The following is a description of a gene set: Vaccination with attenuated live varicella zoster virus (VZV) can prevent zoster reactivation, but protection is incomplete especially in an older population. To decipher the molecular mechanisms underlying variable vaccine responses, T- and B-cell responses to VZV vaccination were examined in individuals of different ages including identical twin pairs. Contrary to the induction of VZV-specific antibodies, antigen-specific T cell responses were significantly influenced by inherited factors. Diminished generation of long-lived memory T cells in older individuals was mainly caused by increased T cell loss after the peak response while the expansion of antigen-specific T cells was not affected by age. Gene expression in activated CD4 T cells at the time of the peak response identified gene modules related to cell cycle regulation and DNA repair that correlated with the contraction phase of the T cell response and consequently the generation of long-lived memory cells. These data identify cell cycle regulatory mechanisms as targets to reduce T cell attrition in a vaccine response and to improve the generation of antigen-specific T cell memory, in particular in an older population. Genes negatively correlated with expansion of VZV specific T cells (0d to peak) in peripheral blood mononuclear cell in seniors (50-75) after exposure to Zostavax, time point 1D from publication Qi Q, Cavanagh MM, Le Saux S, Wagar LE, Mackey S, Hu J, Maecker H, Swan GE, Davis MM, Dekker CL, Tian L, Weyand CM, Goronzy JJ (PMID 27764254) species: Homo sapiens Human Gene Set: QI_PBMC_ZOSTAVAX_AGE_50_75YO_CORRELATED_WITH_EXPANSION_OF_VZV_SPECIFIC_T_CELLS_TO_PEAK_AT_1DY_NEGATIVE, and this is the list of marker genes: TOMM7, H4C3, SF1, DPP9, NSUN5, GIMAP5, EEF1B2 (NCBI Gene Id 1933), TPT1, STAG3L2, MCOLN1, RAD23A, PSMA3, TXNDC17, PSMA6 (proteasome 20S subunit alpha 6), COX6C, FUCA2, VTI1B, GNL3L, ARID4B, BOLA2, ATP5PF, MRPL23, TRIM25, DHX29, CHRNB3, ELMOD3, BNIP3L (BCL2 interacting protein 3 like), AP2S1, SERF2, PQBP1, MRPL36, ZSWIM8, NDUFB2, HINT1, RPL4, ARMH1, CARD14, RPS5, ATRAID, PSMA4, UBE2H, CLC, MRPS24, TMA7, SF3B5, FBXL15, RO60, CDK11A, SEPTIN6, H2AC18, VPREB3, ASS1, NDUFB3, MSL3, MRPS33, CD200, U2AF1, TMC6, CD79B, RPS27, HDAC7, TYMP, MRPL14, DTYMK, MT1E, RNASE2, UQCRQ (ubiquinol-cytochrome c reductase complex III subunit VII), PLEKHB2, ZNF160, DYRK2, CD52, PCYOX1, FAM72B, NUDT1, RPL27, APOBEC3D, DPM2, TMEM238, PVALB, COPZ1 (COPI coat complex subunit zeta 1), RAB27A, USP48, MRPL54, UQCRHL, GPX4, EEF1D, GTF3A, RINL, CXorf38, C7orf50, NDUFA1, MRPL20, SIVA1, WASH3P, CA1, PSMC3, YBX1, COMMD6, ANKRD35, MRPL41, C12orf57, RBM12B, RPL7L1, NAA20, NDUFA13, RPL6, UBE2Z, RRAS, HMGN1, ZNF511, RHOC, MRPL51, ITM2A, DRAP1, C1QBP, CLTB, SEC22C, NBPF20, TRIM38, MARCHF6, RPS27L, VPS25, DAB2 (NCBI Gene Id 1601), SH2D2A, HMGCR, NFAT5, LILRA5, RPS17, RPL11, GZMA, TOMM6, EVI5, OCIAD2, SNHG5, PASK, CLUHP3